Given this list of marker genes TARBP2, DGCR8, XPO5, RAN, DICER1 (dicer 1, ribonuclease III), DROSHA, here is a description of the gene set: miRNA biogenesis Human Gene Set: WP_MIRNA_BIOGENESIS studied in species Homo sapiens